Given this list of marker genes SUZ12, EZH2, PHF19, MTF2, H2BC17, H2AC6, H3C1, EPOP, H2BC5, H2BC11, H2AX, H2BC12L, AEBP2, H2BC9, H2BC26, H4C1, H2BC14, EED, H2BC15, H2AJ, H2AC18 (NCBI Gene Id 8337, H2A clustered histone 18), H2BC12, JARID2, H3C15, H2BC3, DNMT3A, EZH1, H2BC21, H2AZ2, H2BC13, DNMT3B, RBBP4, DNMT1, H2AC20, H2AB1, H2AC4, H2AC7, EZHIP, RBBP7, H3-3A, H2AC14, PHF1, H2BC1, H2BC4, here is a description of the gene set: part of: Epigenetic regulation of gene expression Reactome Pathway: PRC2 methylates histones and DNA studied in species Homo sapiens Polycomb group proteins are responsible for the heritable repression of genes during development. Two major families of Polycomb complexes exist: Polycomb Repressive Complex 1 (PRC1) and Polycomb Repressive Complex 2 (PRC2). PRC1 and PRC2 each appear to comprise sets of distinct complexes that contain common core subunits and distinct accessory subunits. PRC2, through its component EZH2 or, in some complexes, EZH1 produces the initial molecular mark of repression, the trimethylation of lysine-27 of histone H3 (H3K27me3). How PRC2 is initially recruited to a locus remains unknown, however cytosine-guanine (CpG) motifs and transcripts have been suggested. Different mechanisms may be used at different loci. The trimethylated H3K27 produced by PRC2 is bound by the Polycomb subunit of PRC1. PRC1 ubiquitinates histone H2A and maintains repression.